Given this list of marker genes Rbp4, Ror2, Fgf10, Tcf7, Tifab, Ctnnb1, Nipbl, Ar, Trp63, Npr2, Klhl10, Tcf7l2, Neurog1, Sycp2, Lrp6, Shh, Nkx3-1 (NCBI Gene Id 18095), here is a description of the gene set: The process in which the anatomical structures of genitalia are generated and organized. The genitalia are the organs of reproduction or generation, external and internal. Mouse Gene Set: GOBP_GENITALIA_MORPHOGENESIS species: Mus musculus